Given this list of marker genes Casq1, Il10, Pik3ca, Sgca, Hdac4, Drd2, Fbxo32, Dag1, Myog, Cat, Scn5a, Mtmr4, Actn3, Dmd, Trim63, here is a description of the gene set: Any process that results in a change in state or activity of a cell or an organism (in terms of movement, secretion, enzyme production, gene expression, etc.) as a result of an inactivity stimulus. studied in species Mus musculus Mouse Gene Set: GOBP_RESPONSE_TO_INACTIVITY